The following is a description of a gene set: from publication Fan X, Bialecka M, Moustakas I, Lam E, Torrens-Juaneda V, Borggreven NV, Trouw L, Louwe LA, Pilgram GSK, Mei H, van der Westerlaken L, Chuva de Sousa Lopes SM (PMID 31320652) The ovaries analyzed showed a pronounced population of CD53high/CXCR4high immune cells (Fig. 2e), including separate clusters for adaptive T lymphocytes and Natural Killer (NK) cells (CL4 and CL12), B lymphocytes (CL18), and innate immune system, such as monocytes and macrophages (CL13) studied in species Homo sapiens Human Gene Set: FAN_OVARY_CL4_T_LYMPHOCYTE_NK_CELL_1, and this is the list of marker genes: IFITM2, FNBP1, CD69, S100A6, SRSF2, ARPC1B, SUPT4H1 (NCBI Gene Id 6827), APMAP, NOP10, ISCU, EIF1, CHCHD2, HINT1, ISG15, DYNLL1, FXYD5, ATP1B3, GZMA, DOK2, CTSW, JTB, S1PR4, PRRC2C, SF3B2, PGK1, RAB5C, TMBIM6 (NCBI Gene Id 7009), CIB1, CD37, IL2RG, TRAC, SLC3A2, HSPA1A, TAGLN2, CRIP1 (NCBI Gene Id 1396), IDI1, HLA-DRB1, NDUFA6, TAP1, RPS29, ATP6V0E1, SRSF7, CORO1A, POLR2L, PRR13, ATP5F1B, SNU13, ENSA, ELF1, KLRB1, CST7, BTG1, GIMAP7, TRAM1, SNRPB, TRGC2, CCL4, CLEC2D, SH3BGRL3, SYAP1 (NCBI Gene Id 94056), MCL1, HSPA8, ITM2A (integral membrane protein 2A), S100A4, GZMM, ZFP36L2, SOD1, PIK3R1, OAZ1, IL32, YWHAZ, PLAAT4, PKM, CXCR4, CDC42SE1, FAM177A1, CALR, PTMA, YWHAB, CD44, TMEM50A, CD3E, ALOX5AP, S100A11, PPP2R5C, RAN, LRRFIP1, TRBC2, SELENOT, COTL1, CD3D, UBC (ubiquitin C), HOPX, CYTIP, ARPC3, EZR, HLA-DQB1 (NCBI Gene Id 7924), GNG2, AURKAIP1, PAIP2, CD2, ZFP36 (ZFP36 ring finger protein), ARF6, CD247, HLA-A, DDIT4, ADGRE5, CLIC1, LCP1, CREM, KLF6, PABPC1, PTPRC, ARHGDIA, JPT1, GZMK, GZMH, COX6A1, CYBA, NKG7, FLNA, APOBEC3G, C9orf78, S100A10, ARID4B, RGCC, GUK1, TMA7, HLA-DPB1, RUNX3, EMP3, CHST12, RAP1B, ANXA1, CAPZA1, PSMB9, ITGB2, ID2, TGFB1, FGFR1OP2, CFL1, LEPROTL1, EIF5A, PDCD4, PSME2, TCF25, RAB5IF, TPM3, BUB3, CDC37, PFN1, ANXA11, IRF1, ATP5F1E, CDC42SE2, B2M, CD52, CDC42, TMSB4X, GAPDH, LAPTM5, KMT2E, UBE2D3, TUBA1B, HSP90AA1, PPP4C, DBI, HMGB2, HLA-B, RABAC1, GNLY, UBE2A, OASL, GSPT1, UBB, RPS26, JAK1, PLP2, HLA-C, BIRC3 (NCBI Gene Id 330), MYL6, SSR4, PRF1, NAA50, RHOA, PSME1, YPEL5, AKNA, LIMD2, LDHA, CALM1, UBA52, CAP1, LSP1, TRBC1, RBM8A, TUBA1A, LITAF, AKAP13, TSC22D3, MSN, SH2D2A, ARID5A, SARAF, C12orf75, DDX24, DUSP2, KLRD1, FTH1, SURF4, STK4 (NCBI Gene Id 6789), PPP1CA, TERF2IP, ENO1, H2AZ2, PRPF38B, GZMB, WIPF1, PSMA7, TRIR, TNFRSF1B, TUBB4B, HCST, ARHGDIB, BZW1 (basic leucine zipper and W2 domains 1), MRPS6, HLA-E, NDUFB8, DAZAP2, CD7, SAMSN1, ADRM1, MANF, TUBA4A, SRGN, SPOCK2, CCL5, PGAM1, FYN, CD53, ARL6IP5, IFITM1, ISG20, RPL28, SUB1 (SUB1 regulator of transcription), ARPC2